The following is a description of a gene set: The modification of peptidyl-cysteine. Mouse Gene Set: GOBP_PEPTIDYL_CYSTEINE_MODIFICATION studied in species Mus musculus, and this is the list of marker genes: Nos1, Txn1, Adh5, S100a8, Clip3, Zdhhc21, Zdhhc8, Zdhhc15, Zdhhc2, Zdhhc11, Nos2 (NCBI Gene Id 18126), Park7, Oxr1, Rab3b, Rab6a, Snta1, S100a9, Zdhhc18, Golga7, Chchd4, Zdhhc17, Hhat, Rab3d, Zdhhc7, Tbc1d24, Map6d1, Zdhhc20, Zdhhc19 (zinc finger, DHHC domain containing 19), Zdhhc3 (zinc finger, DHHC domain containing 3), Zdhhc9, Prdx3, Ncoa7, Zdhhc12, Zdhhc1, Zdhhc14, Gapdh